Given this list of marker genes FCHSD1 (FCH and double SH3 domains 1), TRIOBP, ARF6, KANK1, ASB2, GHSR, PREX1, CCL11, TMOD4, CARMIL2, DIAPH1, MICAL3, WASF3, PTK2B, SPTAN1, NPHS1, COTL1, BAG4, BBS4, SSH2, CORO7, CYRIB, ARPC2, ARHGAP6 (Rho GTPase activating protein 6), PLEKHH2, CCL26, TWF2, CAPZA1, DIAPH3, PFN2, WASHC3, SPTBN4, SPTA1, NCKAP1, AVIL, ADD2, ABL1, DSTN, WAS, MLST8, PAK3, MIR214, PIK3CA, CRACD, HCK, DAAM2, SPTBN5, GHRL, ABI2, BIN1, SWAP70, SCIN, ARHGAP28, ESAM, CFL1, VASP, MICAL2, MSRB2, LATS1, TMSB4Y, WDR1, NCK2, CCL24, CDC42EP5, SNX9, MYADM, COBL, DLG1 (discs large MAGUK scaffold protein 1), ARFGEF1, MTOR, ADD1, ANG, TMOD3, HCLS1, LMOD3 (NCBI Gene Id 56203), KANK2, CYFIP1, VILL, WASL, CD2AP, PDXP, ARPC3, NCK1, BRK1, ADD3, CARMIL1 (NCBI Gene Id 55604), SEMA5A, CAPG, NCKAP1L, RDX, CAPZA2, PRKCD, PIK3R2, LIMA1, ALOX15, AIF1, ARHGAP35, SPTBN2, INF2, RASA1, FHDC1, RAC1 (Rac family small GTPase 1), MICAL1 (microtubule associated monooxygenase, calponin and LIM domain containing 1), EPS8, PYCARD, F2RL1, SSH3, CAPZB, ARPC5L, PFN3, TENM1, WASHC5, PLEKHG2, WIPF1 (NCBI Gene Id 7456), CXCL12, MSRB1 (NCBI Gene Id 51734), SSH1, WASF1, RHOD, ELN, TMOD1, SPECC1L, KIRREL1, CDC42EP3, SPTB, WASHC2C, CFL2, TMOD2, TTC17 (tetratricopeptide repeat domain 17), CDC42EP1, LMOD2, RICTOR, CYFIP2, BAIAP2L1, VIL1, BAIAP2L2, KANK3, BAIAP2, EVL, CDC42EP2, DIAPH2, CATIP, LMOD1, C15orf62, DMTN, GRB2 (NCBI Gene Id 80715), ABITRAM, ARHGAP40, CCL21, ARPC5, SVIL, ACTN2, PLEK, PPP1R9B, CDC42EP4, FLII, ARPC4, SH3BP1, HAX1, CORO1A, SLIT2, NAA80 (NCBI Gene Id 24142), HIP1R, CCR7, KANK4, FAM107A, ENAH, ABI1, JAK2, MICALL2, PFN1, CSF3, PRKCE, GBA2, TWF1, CYRIA (CYFIP related Rac1 interactor A), CAPZA3 (capping actin protein of muscle Z-line subunit alpha 3), SPATC1L, CTTN, FCHSD2, MKKS (NCBI Gene Id 8195), SPTBN1, GSN, FER, MTPN, ARHGAP18, TMSB4X, here is a description of the gene set: studied in species Homo sapiens Assembly or disassembly of actin filaments by the addition or removal of actin monomers from a filament. Human Gene Set: GOBP_ACTIN_POLYMERIZATION_OR_DEPOLYMERIZATION